The following is a description of a gene set: part of: Developmental Biology Reactome Pathway: Keratinization species: Homo sapiens Keratins are the major structural protein of vertebrate epidermis, constituting up to 85% of a fully differentiated keratinocyte. Keratins belong to a superfamily of intermediate filament (IF) proteins that form alpha-helical coiled-coil dimers, which associate laterally and end-to-end to form approximately 10 nm diameter filaments. Keratin filaments are heteropolymeric, formed from equal amounts of acidic type I and basic /neutral type 2 keratins. Humans have 54 keratin genes. They have highly specific expression patterns, related to the epithelial type and stage of differentiation. Roughly half of human keratins are specific to hair follicles (Langbein & Schweizer 2005). Keratin filaments bundle into tonofilaments that span the cytoplasm and bind to desmosomes and other cell membrane structures. This reflects their primary function, maintaining the mechanical stability of individual cells and epithelial tissues., and this is the list of marker genes: KRTAP5-11, KRT84 (NCBI Gene Id 3890), KRTAP16-1, PKP4, KRTAP5-9, LIPJ, KRTAP3-2, KRT71, KRTAP4-9, KRTAP12-2, KRTAP6-2, LIPN, KRTAP4-8, KRT72, SPRR2G, PERP, SPRR1B, KAZN, KRTAP10-6, EVPL, KRTAP13-1, KRT16, KRT6C, CSTA, KRTAP21-1, KRT35, KLK12, KRT82, KLK8, KRTAP11-1, KRTAP10-7, TCHH, KRT79, KRTAP19-7, PKP3 (NCBI Gene Id 11187), KRT6A, LELP1, KLK5, KRTAP9-2, LCE1A, LCE3E, KRTAP4-6, KRTAP1-4, LIPM, KRTAP10-11, KRT26, KRT33B, KRT14, KRTAP5-2, KRT32, KRTAP24-1, KRTAP9-6, KRTAP19-1, KRTAP4-7, KRT74, KRT7, LCE1E, SPRR2E, KRT15, KRTAP10-10, LCE1C, RPTN, KRT2, LCE4A, CASP14, KRTAP2-4, KRTAP19-2, KRT38, TGM1, KRT3, KRT33A, KRTAP13-3, KRTAP10-3, PKP1, SPINK5, KRT24 (keratin 24), KRTAP10-5, KRTAP22-1, LCE3D, LCE5A, KRT5, LCE1F, DSP (NCBI Gene Id 202512), KRT9, KRTAP20-1, KRTAP3-1, CAPNS1, KRT10, KRTAP19-6, KRTAP3-3, KRTAP5-3, LCE1B, JUP, KRTAP27-1 (NCBI Gene Id 651759), LCE3A, KRTAP10-4, KRTAP10-9, KRTAP2-3, KRTAP4-4, DSG4, KRT12, KRTAP5-7, KRTAP9-3, KRTAP6-3, KRTAP2-1, KRTAP4-3, SPRR2A, KRT78, DSC2, SPRR1A, DSG1, KRTAP5-8, CAPN1, KRT40, KRTAP4-2, KRT6B, KRT19, KRTAP12-3, KRT4, KRTAP6-1, KRT83, LCE1D, PCSK6, KRT76, KRT17 (NCBI Gene Id 5103), KRT85, LCE3B, KRTAP5-4 (NCBI Gene Id 387267), KRTAP12-4, KRT13, KRT80, FLG, KRTAP19-8, KRTAP19-4, KRTAP10-1, CDSN, KRTAP21-2, PPL, PRSS8, KRT23, KRTAP9-4, LCE2B, KRTAP9-9, KRTAP17-1, DSG2, KRT18, FURIN, KRT39, LIPK, LCE3C, KRT20, KRTAP8-1, KRTAP2-2, KLK13, KRTAP26-1, ST14, KRTAP9-1, SPINK6, KRT81, KLK14, KRTAP10-12, KRT75, CELA2A, IVL, DSG3, KRTAP13-4, KRT25, KRTAP4-11, KRTAP15-1, KRTAP1-5, KRTAP9-7, KRT31 (keratin 31), KRTAP5-10, PI3, SPINK9, SPRR3 (small proline rich protein 3), KRTAP5-1, KRT37, KRTAP23-1, DSC3, KRTAP20-2, KRT77, LCE2A, KRT27, DSC1, KRT86, LCE6A, PKP2, KRT73, KRTAP5-5, KRTAP19-5, LCE2C, KRT8 (keratin 8), KRTAP10-2, KRT1, LCE2D, SPRR2F, TGM5, KRTAP1-3, KRTAP12-1, SPRR2B, KRTAP1-1, KRTAP10-8, KRTAP25-1, LORICRIN, SPRR2D, KRTAP4-1, KRTAP29-1, KRTAP21-3, KRTAP4-5, KRTAP5-6, KRTAP13-2, KRT36, KRTAP19-3, KRT28, KRT34, KRTAP9-8